Given this list of marker genes Ppp1r12b, Dmpk, Ppp1r12c, Ppp1r16b, Ppp1r12a, Smtnl1, Ppp1r16a (protein phosphatase 1, regulatory subunit 16A), here is a description of the gene set: Binds to and modulates of the activity of myosin phosphatase. Mouse Gene Set: GOMF_MYOSIN_PHOSPHATASE_REGULATOR_ACTIVITY species: Mus musculus